Given this list of marker genes FADD, XIAP, CASP8, RIPK1, RIPK3 (receptor interacting serine/threonine kinase 3), here is a description of the gene set: species: Homo sapiens Human Gene Set: KEGG_MEDICUS_REFERENCE_REGULATION_OF_EXTRINSIC_APOPTOTIC_PATHWAY_XIAP Pathway Definition from KEGG: XIAP -| (RIPK1+RIPK3+FADD+CASP8) Regulation of extrinsic apoptotic pathway, XIAP. Pathway ID: N01583. Pathway type: Reference. Pathway class: nt06516 TNF signaling.